The following is a description of a gene set: species: Homo sapiens from publication Ji Y, Pos Z, Rao M, Klebanoff CA, Yu Z, Sukumar M, Reger RN, Palmer DC, Borman ZA, Muranski P, Wang E, Schrump DS, Marincola FM, Restifo NP, Gattinoni L (PMID 22057288) Human Gene Set: GSE23568_ID3_TRANSDUCED_VS_ID3_KO_CD8_TCELL_DN Mouse CD8+ T cells affected by ID3 (Inhibitor of DNA binding 3) display patterns of gene expression suggesting enhanced persistance and survival. In this study, we identified genes differentially expressed between ID32a transduced and mock transduced, and ID32a knockout and wild type mouse CD8+ T cells. Most prominent functions of differentially expressed genes include DNA replication-associated repair, maintenance of chromosome stability and mitotic cell divison machinery. Overall, these data suggest that ID3 acts in favor of maintained survival in CD8+ mouse T cells. Genes down-regulated in CD8 T cells: over-expressing ID3 versus ID3 knockout., and this is the list of marker genes: DGKA, CDK16, ABCC5, SBF2, LBP, CIC, PDK1, TNFSF11, ADGRE5 (NCBI Gene Id 976), LDAH, FASLG, CTSH, TNFRSF4, GLCE, RANBP9, CD4, RRN3, USE1, BOD1L1, FBXO38, TNRC6A, CAMLG, ABCF3, IRF6, CCR6, PYGO2, ATP11A, MLX, DNAJA2, TOB1, UBA7, TSPAN32 (tetraspanin 32), CYFIP1, CD83, ZFP36L2, ITM2C, CCR7, MFSD5, ARPC5, PRKCD, CD47, WDR1, CASP7, CFLAR, HNRNPA1, ANKRD40, CA2, RNF138, DMAP1, B2M, SKAP2, SAFB, INPPL1, PKD1, IL27RA, IL10RA, GLTP, SKI, ZMYM4 (NCBI Gene Id 9202), ETS1, SLC30A5, CASP4, ITM2B, ATP6V1D, OGT, RCAN3, EPB41L2 (erythrocyte membrane protein band 4.1 like 2), SNX5, IGKC, ZSCAN26, CYBC1, F2RL1, HLA-B, IL18R1, SLC25A36, NRP1, SPICE1, NXF1, CASP1, ARIH1, BLK, EPS15, CYTIP, HBB, LUC7L, FRMD8, ITGA6, SMAD4, PDE4B, BCL2A1, RRM2B, TAP1, RNGTT, CHD7, DNAJB9, CCDC90B, TULP4, INPP5A, TTC39B, PPID, FAS, DPF2, ATP1A1, ERCC3, ANKH, SNX13, CD9, RPS6, SSBP2, APBB1IP, ZNF841, PDLIM4, CREBBP, AKAP8, UIMC1, TTC17, MATR3, SNX10, ITM2A, SNX2, DDX6, SLC25A20, EZH1, HSD17B11, IL6R, RFLNB, PJA1, IL16, SLC44A1, ZFP36, M6PR, EIF4A2, IL7R, PAN2, TENT5C, IDUA (NCBI Gene Id 3425), CD28, ICE1, NAV2, SPG21, SELL, ANTXR2, PPP1R2P1, OTULINL, RELL1, ST8SIA1, MS4A6A, MCL1, CDC42SE2, TPT1, UPF3B, MS4A1, CR2, AKAP12, EIF4G2, RASSF2, TBCE, ZNF467, CD19 (CD19 molecule), ARHGEF1, SKIC2, TRAF5, RABAC1 (Rab acceptor 1), ORMDL3, PTPN13, PSMB9, DUSP1, GOLGA5, TK2, CFP, YWHAQ, MFHAS1, CD22, SELENOS, HLA-DQA1, DYRK1A, TMEM71, IGLC7, CLCN4, AHNAK, USP19, CXCR5, RAD1, GOSR2, CD6, PPP2R5A, ZFP36L1, GALNT10, CYP4V2, RPL30, MYCBP2, RBM25, BIN1, ENTPD4, ZBTB20, TMC6, VAMP5, ITGB1, PSEN2, DVL1